Given this list of marker genes FBXW7, HPN, XBP1, GLI1, TNFAIP3, RTN4, CEACAM1, TNF (tumor necrosis factor), MED1, SULF2, MDK, LIMS2, CFLAR, PTN, WNT3A, here is a description of the gene set: studied in species Homo sapiens Any process that modulates the frequency, rate or extent of hepatocyte proliferation. Human Gene Set: GOBP_REGULATION_OF_HEPATOCYTE_PROLIFERATION